Given this list of marker genes FLRT1, LRRTM3, AMIGO2, SEMA4A, STAU2, LRTM2, LRRC24, SEMA4D, ADGRB1, EEF2K, NRXN1, ADGRB3, GHRL, BDNF, NLGN1, THBS2, EFNA5, NTRK1, LRRTM1, NLGN2, CBLN1, OXT, FLRT2, ARMCX5-GPRASP2, SRPX2, ADNP, SYNDIG1, AMIGO3, LRRN1, CBLN2, LRRC4B, IL1RAP, CLSTN1 (NCBI Gene Id 22883), WNT7A, SLITRK2, EPHB3, SLITRK3, CUX2, SLITRK4, ADGRB2, NLGN3, ASIC2, LRRN3, SLITRK5, VSTM5, LINGO4, SLITRK1, PRKCA, IQSEC2, AGRN, NTRK3, FLRT3, EPHB1, DLG5, GRID2, EPHB2, IL1RAPL1, AMIGO1, CLSTN3, LRRTM2, SLITRK6, CLSTN2, GPRASP3, PTPRD, NTRK2, LINGO2 (leucine rich repeat and Ig domain containing 2), ST8SIA2 (ST8 alpha-N-acetyl-neuraminide alpha-2,8-sialyltransferase 2), TPBG, here is a description of the gene set: Human Gene Set: GOBP_POSITIVE_REGULATION_OF_SYNAPSE_ASSEMBLY studied in species Homo sapiens Any process that activates, maintains or increases the frequency, rate or extent of synapse assembly, the aggregation, arrangement and bonding together of a set of components to form a synapse.